Given this list of marker genes ARMC5, GNAS, PRNP (prion protein (Kanno blood group)), KDM1A, SLC25A13, here is a description of the gene set: Mania A state of abnormally elevated or irritable mood, arousal, and/or energy levels. Human Gene Set: HP_MANIA studied in species Homo sapiens